Given this list of marker genes KCNA1, CCNJ, PDGFRA, HYCC2 (hyccin PI4KA lipid kinase complex subunit 2), GOLGA8T, UNC5D, PLAG1, HRH1, MBTPS2, BRWD1 (bromodomain and WD repeat domain containing 1), SEC24C, MYBL1, PPP2R3A, PDE3A, RAB3IP (RAB3A interacting protein), CARM1, IGF2BP2, IKZF5, ZNF559, NAP1L1, LRBA, DLG2, ATP8B2, TBPL1, NEK7, G3BP2, ADARB1, MS4A1, ZNF563, SLC25A37, PHIP, ARL5A, AK9, PCDHA11, ENAH, SLITRK1, TBC1D1, BTBD3, PCDHAC1, NLN, RAI1, ABTB2, SESN3, HCN2, TM9SF4, GOLGA8J, COX15, PHTF2, RECK, TOM1L1 (NCBI Gene Id 10040), AP1S3, MIDEAS, TNFRSF11B (TNF receptor superfamily member 11b), UBP1, ZFP14, GSE1, BOLL, GRM5, KANK1, AHCTF1, ZNF584, GPBP1, JADE2, WNK1, ARHGEF3 (Rho guanine nucleotide exchange factor 3), BMP2K, CPEB4, NAB1, SLC5A9, RNF169 (NCBI Gene Id 254225), MED26, PER3, CFAP161, RAB8B, CTTNBP2NL, ONECUT2, FHIP1A, N4BP2, LCLAT1, BCL2, DDX3X, KMT2A, PALS1 (protein associated with LIN7 1, MAGUK p55 family member), TNRC6B, ZNF268, GATA6, SACM1L, SPIRE1, SLC38A11, KLHL5, PRTG, AGO4, CNKSR2, TMLHE, NUS1, ZNF37A, ARMC8, SOWAHA, ZNF800, VPS41, CNKSR3, CPD, ZNF781, IL1A, C2orf69, TPRX1, PLCL2, PAWR, NR1D2, SEMA4G, FNDC3B, GPD1L, LRRC8D, CPOX, KLHL2, FAM3C, SPP1, FOXP1 (forkhead box P1), PCDHA2, ZBTB2, SYT16, TNPO1, GPRIN3, SAMHD1, RAB3GAP1, BEND3, THRB, ZFP36L1, CNTN4, ZNF440, MTF2, CDON, RLF, GTSE1, ZNF140, OSBPL8, TMEM144, HOXA1, SMAP1, PPP3R1, RASSF1, SIK3, NCALD, NEXMIF, LAMA1 (NCBI Gene Id 3907), ASPH, ADAMTS5, XPO7, TRIM71, PCDHA4, PITPNB, HEATR3, SERTAD2, CREBRF, NOTCH4, MARK1, TAB3, SSX2IP, SYNPR, PTPN4, PRR27, RNF217, MAP2K1, PTPDC1, KLHL29, SSB, OTOGL, ZNF121, SLC35F3, LIN28A, KIAA1549L, ZNF594, ZFP1, ZNF468, DNAJA4, ATP2A2, DNAJC3, PHACTR4 (phosphatase and actin regulator 4), MSANTD3-TMEFF1, RNF182, NIPBL, PARP11, SCHIP1, ZFAND4, FSBP, EPHA4, TMEM165, CCL8, SRGAP2, SLC25A36, YTHDC2, WSB1, SELENOT, ENTPD6 (ectonucleoside triphosphate diphosphohydrolase 6), DUSP6, ZNF844, ZNF302, ACAP2, FGD4, OSBPL2, TMEM87B, DARS1, TBC1D4, CHIC1, ZBTB4, RPS6KA3 (ribosomal protein S6 kinase A3), GCC2, MTURN, PTPN22, SLC12A5, TMED4, IPO8, KPNB1, EXOC5, FIGN, NCOA2, TCFL5, AKIRIN1, RAD54B, CHMP2B, CA8, GOLGA8N, CXCL9, DERL1, ABHD18, ASAH2B, TCERG1, MB21D2, NR6A1, RNF34, KLF15, ASTN1, MTPN, UBE2B, MFSD6, FBXO33, PCDHA7, SIPA1L2, PNRC2, USP33, PRKCD, PPIP5K2, LIMCH1, RAD21, PBX3, AGFG1, BRAP, FNIP2, LARP4, IL2, PEAK1, UBE2D3, MAMDC2, ZNF266, KCNJ10, ST6GALNAC5, GIGYF1 (NCBI Gene Id 64599), C2CD5, TRIM2, IPO7, PCDHA1, TMEM131, ANO1, LPCAT2, ACVR2A, ZNF773, KPNA1, REPS2, TBC1D14, ITGA3, FAM135A, SEC24A, AKIRIN2, BRD1, KIF1B, ZFP62, TNFAIP1, CALCR, ADGRB3, LRRN1, PIAS1, ZNF527, ADCY9, FNDC3A, BLOC1S6, PABIR2, RASSF8, FKBP1A, PKNOX2, CHMP1B, NSUN7, TNF, DYNC2H1 (dynein cytoplasmic 2 heavy chain 1), LYRM1, TNFSF4, TREML4 (triggering receptor expressed on myeloid cells like 4), CLIP1, YTHDF3, TTC39B, ZNF189, ZNF544, LGALSL (galectin like), NKAIN2, FUT9, ZNF439, IGDCC3, CRIM1, ETNK1, KCNH1, GOLGA6L4, NLK, TAOK1 (TAO kinase 1), ACER3, AKAP6, QKI, NAA50, OSBPL3, RIMKLB, KRBOX4, AMER2, PCDHA8, CDH8, HMBS, PRDM4, GSKIP, CPNE2, OGFRL1, PAK5, KAT2B, ATMIN (ATM interactor), TRDN, QSER1, GOLGA1, MIER3, WDR82, CDC40, ZNF586, MBOAT2, SALL4, RPS6KB1, IRS2, MAN2A1, SLAIN2, GOT2, BCLAF1, ANKRD13C, SLC35E1, TESMIN, CLVS1, PNISR, SS18L1, PHLDA1, YLPM1, SLC7A11, ZNF479, RALGAPB, UBL3, GABRA1, DNAJC13, SH2B3, SRSF7 (serine and arginine rich splicing factor 7), PPFIA1, TAB2, SIN3B, ETFBKMT, ATP2B1, ZNF780B, LEMD3, CEP97, DISC1, MYO1E, STXBP5, LIG4, ST8SIA4, ADAMTS6, LCTL, APOO, DOCK4, ZEB2, KLF6, ZNF823, PCDHA12, TOGARAM1, NR4A3, CPSF6 (cleavage and polyadenylation specific factor 6), RAB30, TCF7L2, S1PR1, TNS1, MUC7, CBFA2T3, CDKN3 (NCBI Gene Id 1033), ARF6, KIF3A, PRRC2C, AP1G1 (adaptor related protein complex 1 subunit gamma 1), TXNDC12, SLC10A7, TENT4B, PSG11, PSPC1, EYA3, SLC4A10, PROX1, PAPOLG, ARMH4, GRB10, CCNK, GHITM, MLXIP, PCSK1, MTX3, LNPK (lunapark, ER junction formation factor), POU2F1 (POU class 2 homeobox 1), ZNF700, ADAM11, PRLR, PARM1, ATM, BAZ2B, CBLB, MCC, PLAU, PDAP1, ANKRD44, HIPK3, B4GALT1, OXGR1 (NCBI Gene Id 65974), RIOX2, DMXL2, LIN28B, ZDHHC17, ATP2B2, PAFAH1B2, ZNF597, UBE3C, GPD2, CDC73, EN1 (NCBI Gene Id 2019), RASSF2 (NCBI Gene Id 9770), NOVA1, PCDHAC2, GPR137C, NUCKS1, ETS1, LATS1, RORA, NPEPPS (NCBI Gene Id 9520), TMEM94, AFG3L2 (AFG3 like matrix AAA peptidase subunit 2), PCDHA9, BHLHE40, KCNQ5, EPC2, DCBLD2, CDK17, KLHL42, MAPK1IP1L, NAALADL2, CHD1, JARID2, TRAK1 (trafficking kinesin protein 1), ZIC3, AKT3, ESM1, ZNRF2, CCNDBP1, GOLGA8H, ZBTB43, ADO, RLIM, TMEFF1, TMF1, HAO1, MYCBP2, TGFBRAP1, PAM, TAFA2, HECA (NCBI Gene Id 51696), RFC1, DCN, HOXD1, IPMK, PCDHA6, NELFA (NCBI Gene Id 7469), CDYL, BAG4, ZFP90, DCLK1, GOLGA8R, KMT2C, NR2C2, PHF20L1, C14orf28, DEPTOR, CBX7, HEY2, FSD1L, APBA1, ZDHHC7, PLEKHJ1, NIPAL4, BCL2L11, POLQ, ATXN1, PI4K2B, PAX9, ADCY1, E2F5, PCDHA5, CREB1, LPCAT1, CCP110, ATXN3, AIRIM, GOLGA8M, LMO1, PCDHA13, ZNF124, ZFAND6, SLC4A8, GLS, NOTCH2, PHF3, ZNF426, DEK, PCDHA10, RAB3C, RBBP7, CDC5L, NWD2, MEGF9, LOX, TADA2B (transcriptional adaptor 2B), RYR3, ATP2B3, ACSL4, NMBR, GOLGA8Q, SIX4, PDE5A, HSP90B1, ACVR2B, STARD4, MBNL2, INO80D, ZNF780A, HIC2, UNC80, ADRA1A, OOSP2, MUC22, E2F7, ATP1B1, UBE2D1, AP1AR, KIF3B, AASDHPPT, SLC2A3, PTBP3 (NCBI Gene Id 9991), IQCJ-SCHIP1, TBCEL, KATNBL1, MAP3K3, PAX5, ZNF704, CD69, NRXN1, TRDMT1, ETV6 (NCBI Gene Id 4348), SPECC1L, CALM1, SCD, ZDHHC3, PCDHA3, BIRC6, ESR1, EYS, ATXN7, CLASP1, TGFBR1, CNOT2, MGAT2, ADAMTS18, CTDSPL, MORC3, FBXO34, HOXC8, KDM5A, TMEM64 (transmembrane protein 64), OTUD4, CECR2, PNMA2, SPRY4, GRIK2, HOXA11, ARSJ, ZFP36L2, ZIC2, MICU3, USP42, here is a description of the gene set: Genes predicted to be targets of miRBase v22 microRNA hsa-miR-181a-5p, hsa-miR-181b-5p in miRDB v6.0 with MirTarget v4 prediction scores > 80 (high confidence targets). from publication Chen Y, Wang X (PMID 31504780) studied in species Homo sapiens Human Gene Set: MIR181A_5P_MIR181B_5P